The following is a description of a gene set: species: Homo sapiens Human Gene Set: GOBP_NEGATIVE_REGULATION_OF_SCHWANN_CELL_PROLIFERATION Any process that decreases the frequency or extent of the multiplication or reproduction of Schwann cells, resulting in the expansion of their population. Schwann cells are a type of glial cell in the peripheral nervous system., and this is the list of marker genes: ASCL2, NF2, CERS2, SOX10, DICER1, SKI, RNF10, NF1